The following is a description of a gene set: Human Gene Set: GOBP_REGULATION_OF_ARTERY_MORPHOGENESIS species: Homo sapiens Any process that modulates the frequency, rate or extent of artery morphogenesis., and this is the list of marker genes: EDN1, MIR153-1, MIR494, MIR495, MIR205, EFNB2, MIR487B, MIR29B1, NOTCH1 (NCBI Gene Id 54781), MDK, NFATC3, RTN4, AKT3, MIR329-1